Given this list of marker genes RRAS2, IL18R1, METTL1, ADARB1, SCRIB, ANKLE2, R3HDM1, TM9SF1, GEMIN4, FASLG (NCBI Gene Id 356), PHB1, NPM3, IDH3A, PEX3, SPRY1, PSMD1, LAMA2, FADD, IDI1, UTP18, AGO2, NEFH, MMACHC, UNG, UBE2G2, SNRPC, PPP2CA (protein phosphatase 2 catalytic subunit alpha), HPRT1, DUSP5, UTP14C, PWP2, VCP, ATP10D, POLR2G, LAMP3, HCCS, TXNDC9, NUP133, PCCB, NHP2, WDR43, MRPS27, EIF4E2, CAND1, PGAP1, FXN, MAPKAPK3, RAB27A, PPP1CC, ALG8, EIF3J, DCUN1D4, CDK4, PSMB5, HPS5, PSMA6, PPAT, MTREX, ENO1, OAT, CALU, MAPRE2, UAP1, STK4, DNAJC3, BCAT2, TIMM17A, UBA2, ABCF2, SNU13, RCAN1, ZBTB24, PER2, FARSA, CD28 (CD28 molecule), CCL4, WNK1, CCT4, HOMER1, EIF4A1, FKTN, HDDC2, SNX17, NUP88, SQLE, IL12RB2, COPS8, SNHG3, BET1, TRIP13, SRGN, IL1R1, ZNF75D, PA2G4, SRR, NFATC1, NOP56, HNRNPA3, IMMT, CHSY1, RRP7A, PSMB6, LPCAT1, TFCP2, EXOC3, MRE11, FUS, HYOU1, AK2, UBE2V2, HNRNPF, CD48, LPL, SUCLA2, PNP, NELFE, WDR47, SRPK1, TUBA1B, PDS5A, HSP90AB1 (NCBI Gene Id 3326), CD226, UTP25, HMGN4, RPN2, IL18RAP, ZNF195, MTA1, MAMLD1, RPA3, MYDGF, MARS1, RFC4, FAM98A, IQCB1 (NCBI Gene Id 9657), GGCT, SLC3A2, NUTF2, KRIT1, CANX, POP1, NT5E, PDCD2, NSMAF, PSMD7, LYST, LYSET, CPSF4, NCKAP1, ATP1B3, GFUS, SORD, MIF, AATF, ADO, CCDC86, NDUFS6, QDPR, TNF, PPT1, XPOT, NUP160, PPRC1, EIF3I, NKRF, PEA15, PDIA5, CFLAR, CDK2AP1, C1orf216, EXOSC8, IPO5, ELMO1, PWP1, SENP6, RGS10, NME1, PDIA3, URB2, MRPS12, ZNF200, AHCY, PKM, RHOG, PMS1, GNG5, RCN1, POP4, TXN, GTF2E2, PRR3, RFC3, DIMT1, SEL1L (SEL1L adaptor subunit of SYVN1 ubiquitin ligase), SNRPD1, PSMB3, VDAC3, SRM, LSM7, IL2RA, here is a description of the gene set: species: Homo sapiens Human Gene Set: GSE24574_NAIVE_VS_TCONV_CD4_TCELL_DN from publication Kitano M, Moriyama S, Ando Y, Hikida M, Mori Y, Kurosaki T, Okada T (PMID 21636294) We found that a number of Tfh cells downmodulated BCL6 protein after their development, and we sought to compare the gene expression between BCL6-hi Tfh cells and BCL6-low Tfh cells. Genes down-regulated in naïve CD4 Tcells versus T conv cells.